The following is a description of a gene set: Mouse Gene Set: GOBP_REGULATION_OF_AGGREPHAGY species: Mus musculus Any process that modulates the frequency, rate or extent of aggrephagy., and this is the list of marker genes: Htt, Hdac6, Lypla1, Zdhhc19 (zinc finger, DHHC domain containing 19), Bag3, Kat5, Hspb8, Csnk2a1